The following is a description of a gene set: studied in species Homo sapiens from publication Hill JA, Feuerer M, Tash K, Haxhinasto S, Perez J, Melamed R, Mathis D, Benoist C (PMID 18024188) Human Gene Set: GSE7460_TREG_VS_TCONV_ACT_WITH_TGFB_DN Genes down-regulated in comparsion of ActTregTGF versus ActCD4TGF (see Fig. 1 in the paper for details). The transcription factor Foxp3 is usually considered the master regulator for the CD4+CD25+, and this is the list of marker genes: RPL19, CREB3L4, RDH5, TBC1D21, PARD6A, MORC1, BLOC1S6, MYRIP, ADIPOR2, MYO10, HVCN1, CFAP157, MFHAS1 (NCBI Gene Id 9258), EEF1G, SSTR3, CHD7, PRM2, PFN3, MTUS1, FAM98C, MIIP, PCYT2, TMEM273 (transmembrane protein 273), ST3GAL1, HPCAL1, ANGPTL8, CARD11, ARHGEF10, APOBR, MRPL33, ZNF526, ARL4C, SNX32, PHF10, SIRT7, DAPK3, ANXA1, TMEM219, TPST2, PAQR7, HDAC4, MVD (mevalonate diphosphate decarboxylase), SERTAD1, LINC01160, AGT (NCBI Gene Id 183), CORO6, NEB, RPLP0, KCNN4, TMEM94, CCDC169, PDLIM4, P2RX7, NUB1, RPS8, CAPN10, KHK, TRAF3IP2, SH2D1A, SURF4, BCKDHA, DENND1A, ZBTB17, SIGIRR, RHOD, LARGE1, ODR4, COQ3, INTS5, CCDC17, RUNDC3A, NAPA, ADCK5 (aarF domain containing kinase 5), MAN2A2, DENND3, GSTT2, GPR18, REG1A, ACD, NOL12, H19, GPR20, PLIN3, TIMP4, MRPL4, B3GALNT2, APPL2, CTSA, ANGPTL4, CTSD, WDFY1, EIF4H, ACTR3B, TMEM71, NUDT18, GATD3, CLDN15 (NCBI Gene Id 245814), LDLR, UCK2, RBM38, ZNF787, RPS3A, ABHD15, CHID1, NEURL4, PRKCSH, AKR7A2, MPND, ENGASE, SH3GL1, HLA-DOA, ZFYVE21, ZDHHC18, OSBPL2, SPATA46, RPL7A, TBC1D22A, CD2 (NCBI Gene Id 914), NEDD4L, ACP5, INKA1, DAPL1, RPL3, UBXN11, ENC1, UBXN6, ITCH, ST6GALNAC5 (ST6 N-acetylgalactosaminide alpha-2,6-sialyltransferase 5), PGM5, ARL5A, INSIG1, VWA8, OGFR, CCDC150, CYB561D1, MYL10, RTF2, KEAP1, HS3ST3B1, SEMA4A, GPAT2, C21orf58, RHBDF2, PPIC, LPP, POR, GIMAP1, ENSG00000267882, PNMA8A, TMEM229B, DAP, ABI3, HS3ST4, KLK8, TECPR1, MTMR14, CEND1, GLMP, MGLL, HRCT1, UNC45A, FERMT3, PMM2, IKBKB, EBI3, EME2, TNNT1, FASTK, PLD3, ZFP64, FAM78A, DNAAF4, CD276, HCST, RPSA, TM7SF2, TSTD1, VPS26C, NDUFA9, GCM2, PGGT1B, ACSS2, TRABD, LEF1, DNAJB2, ARHGAP26, FASN, OXCT1, ZNF341, DKKL1, CRADD, MGAT3, SQSTM1, ST8SIA5, EEIG1, ZBTB7B, RRAD, NTRK3, HMGCL, RAD52